The following is a description of a gene set: Genes predicted to be targets of miRBase v22 microRNA hsa-miR-377-5p in miRDB v6.0 with MirTarget v4 prediction scores > 80 (high confidence targets). from publication Chen Y, Wang X (PMID 31504780) species: Homo sapiens Human Gene Set: MIR377_5P, and this is the list of marker genes: TRPM7, MYO5C, ZNF273, LAMP5 (NCBI Gene Id 24141), FKBP5, ACAT2, CDH10, CCDC89, CDK14, TFPI, COL5A1, TEX56P (testis expressed 56, pseudogene), ZC3H4 (zinc finger CCCH-type containing 4), FKBP1A, KRTAP8-1, ZNF483, ADGRB3, MYEF2, ASIC1, FBN2, TRIO, PSG4, PITPNM2, SLC37A3, ACER2, DDA1, JCAD, HTR4, ROBO1, EIF5A2 (NCBI Gene Id 57114), NCOR1, PSG1, PAPOLA, NCOA1 (NCBI Gene Id 8648), EPO, PRRC1, TSPYL1, ANGPTL4, MSL2, ZFP82, SYT11, TMEM30B, FBN3, MTX2, BATF2, ACBD5, CHTF8, PSG7, ZNF234, TMEM167A, ARRB2, AGO1